Given this list of marker genes CSF2RA, LAPTM5, FCGR2B, TYROBP, GRK2, PTPRC (protein tyrosine phosphatase receptor type C), DDX18, RRP7A, ZNF653, MIR142, SLC66A3, IGHV1-24, TCF25, CUL2, LYZ, SLFN12, BMAL1, MAZ, ZNF688, IGKV1D-43, ALDOA, DDX52, FAS, MSC, SLC38A4, FMNL1, ASH1L, IGHV2-26 (immunoglobulin heavy variable 2-26), IGHG3, IGHG1, CD48, IGLV4-69, CCL8, BRIX1, MRPL41, S100A8, PDE7A, NONO, HHEX, UBD, IGKV4-1, SLPI, RNASE1, IGLC1, PIP4K2A, IKZF1, FERMT3, IGKV5-2, IFIT1B, BAG6, MBTD1, PLEKHO1, HTR1D, IGLV2-18, IFITM3, SAAL1, IGLV1-50, KNG1, IGHV3-43, ZCCHC3, IL18R1, CFP, RNF38, IGHV1-58, INCENP, GBP2, EIF4EBP2, CD79B, ALDOC, EMP3, IGHM, ADH1A, SUGT1, RAD51AP1, IGKV1-27, PSMB9, UNC93B1, CCR2, S100A9, CXCL13, C9orf40, SELPLG, CCNJ, EVI2A, TMEM70, CCL15, SEC61A2, CXCR4 (NCBI Gene Id 93405), CXCL9, MS4A1, IL1R2, IGHV1-2, IGKV2D-30, IGKV2D-29, IGKV1-9, RHOH, ACIN1, CCL5, PTP4A3, here is a description of the gene set: Human Gene Set: RASHI_RESPONSE_TO_IONIZING_RADIATION_6 from publication Rashi-Elkeles S, Elkon R, Weizman N, Linhart C, Amariglio N, Sternberg G, Rechavi G, Barzilai A, Shamir R, Shiloh Y (PMID 16314843) The ATM protein kinase, functionally missing in patients with the human genetic disorder ataxia-telangiectasia, is a master regulator of the cellular network induced by DNA double-strand breaks. The ATM gene is also frequently mutated in sporadic cancers of lymphoid origin. Here, we applied a functional genomics approach that combined gene expression profiling and computational promoter analysis to obtain global dissection of the transcriptional response to ionizing radiation in murine lymphoid tissue. Cluster analysis revealed a prominent pattern characterizing dozens of genes whose response to irradiation was Atm-dependent. Computational analysis identified significant enrichment of the binding site signatures of NF-kappaB and p53 among promoters of these genes, pointing to the major role of these two transcription factors in mediating the Atm-dependent transcriptional response in the irradiated lymphoid tissue. Examination of the response showed that pro- and antiapoptotic signals were simultaneously induced, with the proapoptotic pathway mediated by p53 targets, and the prosurvival pathway by NF-kappaB targets. These findings further elucidate the molecular network induced by IR, point to novel putative NF-kappaB targets, and suggest a mechanistic model for cellular balancing between pro- and antiapoptotic signals induced by IR in lymphoid tissues, which has implications for cancer management. The emerging model suggests that restoring the p53-mediated apoptotic arm while blocking the NF-kappaB-mediated prosurvival arm could effectively increase the radiosensitivity of lymphoid tumors. studied in species Mus musculus Cluster 6: late responding genes activated in ATM deficient but not in the wild type tissues.